Given this list of marker genes COX11, AMACR, COX6A1, MTMR9, SRM, AK5, ACSBG1, SMG6, CLASP2 (NCBI Gene Id 440948), MTMR14, KCNAB1, PIGF, PSG11, EEF2KMT, TSPO, MAL, SAFB, CALHM2, ZNHIT1, SFN, SLC4A2, TNNI2, GC, EIF5A, TLX3, ACAP1, C10orf95-AS1, ARR3, ADRA2A, LINC00574, DRD1, CD207, CDC25C, TTLL3, HAO2, NTN1, S100A10, MED23, OR1G1, HDAC5, TYROBP, SEL1L3, EIF3G, ZGPAT, SCHIP1, PPDPF, FAM50A, CIB1, OR10H3, DDRGK1, RAB4B, VRK3, KCNJ5, KRT18 (keratin 18), NCKIPSD, SDC2, TMSB10, DGUOK, SAP30BP, BRAP (NCBI Gene Id 8315), RUSF1, RIC8A, TYR, VIPAS39 (NCBI Gene Id 63894), SRPX, FES, GSTM5, OAZ1, ACTL6B, SMPD3, TRIM21, SERF2, SLC66A2, FGD2 (NCBI Gene Id 221472), TRIP10, HDLBP, BEX4, DDX23, PCYT1A, TAGLN2, SEMA3G, NUMA1, WT1-AS, LGALS1 (NCBI Gene Id 3956), SPA17, C3orf52, STOML1, GCHFR, RALY, RNASE2, GPR75, NEAT1, IL16, UPP1, BTNL2, TXN2, FTSJ3, GDPD5, VASP, LINC03124, MTOR, DND1, PLPPR1, PDLIM7, CHST5, KLF8, RAF1, COQ8B, OGDH (NCBI Gene Id 4967), GBE1, CLN8, CD151, BCL7A, MACROH2A2, STRN4, WAS, CEACAM6, OTUB1, ATP9A, RTF1, RAD54L, SP100, GABRA1, RAP1GAP2, NALF2, KCNA2, POLR3K, NDUFB1, TCIRG1, IVD, STK10, CST3, GFI1, SART1, NRBP1, PSMD11, PXMP4, PI15, NFKBIE, SPINK4, ANXA2P1, ODF1, SH2D4A, DHX30, GOLT1B, ENPP4, FLAD1, OS9, TKFC, ENPP2, CALR, SSR4, TWSG1, MUC5B, ENSG00000274253, ASGR1, SCAF4, TPM4, CTTN, EFHD2 (EF-hand domain family member D2), CANT1, GSTO1, IGF2BP3, SH3BP2, FGF20, FOXF2, EPS15L1, ARF5, EHBP1L1, SOCS3, SGCE, TEAD4, C1QA, SMOX, MICA, RPS6KA2, PLN, PRKD1, ACO2, ANK2, RIPOR1, DDAH2, HEXIM1, GPI, OR2H2, ARL2, MEN1, ZDHHC14, TLE5, DDX24, ZNF212, FIS1, ROR1, OR12D3, INPP5D, here is a description of the gene set: Genes down-regulated in comparison of monocytes from LAIV influenza vaccinee at day 7 post-vaccination vesus those from TIV influenza vaccinee at day 7. Human Gene Set: GSE29618_LAIV_VS_TIV_FLU_VACCINE_DAY7_MONOCYTE_DN from publication Nakaya HI, Wrammert J, Lee EK, Racioppi L, Marie-Kunze S, Haining WN, Means AR, Kasturi SP, Khan N, Li GM, McCausland M, Kanchan V, Kokko KE, Li S, Elbein R, Mehta AK, Aderem A, Subbarao K, Ahmed R, Pulendran B (PMID 21743478) Systems vaccinology has emerged as an interdisciplinary field that combines systems wide measurements and network and predictive modeling applied to vaccinology. Here we used the systems vaccinology approach to study the molecular mechanisms underlying th studied in species Homo sapiens